The following is a description of a gene set: Human Gene Set: WEBER_METHYLATED_LCP_IN_FIBROBLAST_UP Methylated germline-specific genes with low-CpG-density promoters (LCP) in primary fibroblasts. To gain insight into the function of DNA methylation at cis-regulatory regions and its impact on gene expression, we measured methylation, RNA polymerase occupancy and histone modifications at 16,000 promoters in primary human somatic and germline cells. We find CpG-poor promoters hypermethylated in somatic cells, which does not preclude their activity. This methylation is present in male gametes and results in evolutionary loss of CpG dinucleotides, as measured by divergence between humans and primates. In contrast, strong CpG island promoters are mostly unmethylated, even when inactive. Weak CpG island promoters are distinct, as they are preferential targets for de novo methylation in somatic cells. Notably, most germline-specific genes are methylated in somatic cells, suggesting additional functional selection. These results show that promoter sequence and gene function are major predictors of promoter methylation states. Moreover, we observe that inactive unmethylated CpG island promoters show elevated levels of dimethylation of Lys4 of histone H3, suggesting that this chromatin mark may protect DNA from methylation. species: Homo sapiens from publication Weber M, Hellmann I, Stadler MB, Ramos L, Pääbo S, Rebhan M, Schübeler D (PMID 17334365), and this is the list of marker genes: CATSPER3, OAZ3, H1-7, ODF1, MS4A5, CCIN, CATSPER1, CST8, FSCN3, KLHL10, SPACA4, SPATA3, TNP1